The following is a description of a gene set: Cytokines mediate cell-cell communication in the immune system and represent important therapeutic targets. A myriad of studies have highlighted their central role in immune function, yet we lack a global view of the cellular responses of each immune cell type to each cytokine. To address this gap, the authors created the Immune Dictionary, a compendium of single-cell transcriptomic profiles of more than 17 immune cell types in response to each of 86 cytokines (>1,400 cytokine-cell type combinations) in mouse lymph nodes in vivo. A cytokine-centric view of the dictionary revealed that most cytokines induce highly cell-type-specific responses. For example, the inflammatory cytokine interleukin-1β induces distinct gene programmes in almost every cell type. A cell-type-centric view of the dictionary identified more than 66 cytokine-driven cellular polarization states across immune cell types, including previously uncharacterized states such as an interleukin-18-induced polyfunctional natural killer cell state. species: Mus musculus from publication Cui A, Huang T, Li S, Ma A, Pérez JL, Sander C, Keskin DB, Wu CJ, Fraenkel E, Hacohen N (PMID 38057668) Genes negatively differentially expressed in cell type: cDC1 (conventional dendritic cell type 1) upon treatment with cytokine: IFN-α1 in mouse lymph nodes in vivo. Mouse Gene Set: CUI_CDC1_IFNA1_RESPONSE_DN, and this is the list of marker genes: Exosc5, Lamtor2, Foxp1, Fam50a, Ndufs7, Prpf40a, Pdia5, Mrpl57, Snx21, Brd3, Gltp, Psmd2, Pold4, Yeats4, Lmo4, Mink1, Zfp106, Tsc22d3, Prkar2a, Agpat5, Cd300c2, Sec11a, Mrpl12, Fam168b, Wdfy4, Parp1, Eef1e1, Dock2, Grk2, Macf1, Ncor1, Erp29, Kctd12, Fubp1, Hmgb1, Cdc26, H2-DMa, Atp13a3, Rab32, Slc4a7, Rtcb, Unc119b, Pld4 (NCBI Gene Id 217885), Uba52, Shtn1, Camk1d, Nckap1l, Zfp36l2, Glud1, Mrpl52, Ptpre, Lrrk2, Eif4b, Pianp, Ano6, Mrpl34, Itgb7, Uqcr10, Eif3e, Mef2c, Atrx, Ivns1abp, Atp6v0b, Mphosph8, Echs1, Polr1d, Stt3a, Eif4ebp2, Rsl1d1, Hsp90b1, Cbx3, Lyz2, Nap1l1, Set, Ighm, Cd81, Phactr2, Ccr2, Trf, Paip2, Grap2, Bnip3l, Slc25a5, Mapk14, Mak16, Acadm, Polr2f, Clec12a, Pgls, Polr2e, Cers5 (NCBI Gene Id 71949), Ccr5, Laptm5, Nolc1, Atic, P2ry10, Hnrnpa0, Asnsd1, Pes1, Zfp422, Cct2, Naca, Trmt112, Ddx46, Septin3 (NCBI Gene Id 78356), Bmyc, Rtl8a, Llph, Nr2c2ap (NCBI Gene Id 75692), Eif2a, Glrx5, Tubb2a, Ubash3b (NCBI Gene Id 72828), Gpx4, Cdk6 (cyclin dependent kinase 6), Igsf8, Unc119, Mxd4, Sf3b2, Rtl8b, Tmem147, Tmco1, Gspt1 (G1 to S phase transition 1), P4hb, Armc8, Cks2, Mbd3, Banf1, Nfam1, St3gal4, Fth1, Ufsp2, Prdx6, Pabpc1, Timm13, Snrpa, Sec11c, Eif3g, Adss1, Fnbp1, Dhrs7, Lamtor4, Hepacam2, Atp5mc2, Adcy7, Pa2g4 (NCBI Gene Id 18813), Slc1a5, St8sia4, Ap1b1, Rnf130, Cnih4, Ccr9, Tmem238, Ift20, Eeig2, Pgs1 (phosphatidylglycerophosphate synthase 1), Tm9sf3, H2aj, Rnf150, Eef1a1, Rcc2, Creg1, Cnpy2, Coro1a, Syngr2, Gdi2, Nhp2, Vps35, Trp53, Lrwd1, Dnajc2, Eef2, Phb2, Ctnnbip1, Usf2, Kcnq1ot1, Arhgap9, Zftraf1, Eif4a2, Rgs10, Ppig, Kit, Nxf1, Trim28, Stap1, Ucp2, Tubb5, Smc4, Cnbp (NCBI Gene Id 12785), Ifngr1, Sod1, Fam162a, Aimp1, Plekha5, Sgpp1, Parvg, Cd44, Bola2, Hspd1, Nr4a2, Dock10, Ran, Prpf19, Eef1d, Ptpn18, Irak1, Cebpz, Ypel3, Alox5ap, Hint1, Nedd8, Cdk4, Sh3bgrl3, Srm, Sars1, Phf3, Fyb1, Mospd1, Hagh, Mlec, Rgs2, Lyz1, Gpx1, Jun, Epb41l4aos, Tbc1d9, Romo1, Tnrc6b, Trim7, Anp32b, Dusp1, Tbc1d22a, Rp9, Mrps18b, Tmem141, Xpr1, Pten, Krtcap2, Cd37, Pgp, Fcgrt, Ap2a2, Iars1, Rad50, Arhgap18, Tomm40, Ctdp1, Eif3k, Nop58, Apex1, Tm2d2, Xist, Eef1g, Prkcsh, Trps1, Eif2b2, Npm3, Ppp1r14b, Fermt3, Parp8, Ptma, Pdcd4, Dkc1, Matr3, Igsf6, Il16, Sgk1, Ttc39a, Naa38, Clk1, Rnf7, Itga1, Prcp, Slc50a1, Septin11, Scd2, Myo1f, Mri1, Canx, Tomm5, Wipf1, Polr2h, Uqcr11 (NCBI Gene Id 66594), Alcam, Asap1, Upf3b, Atf6b, Hnrnpa1 (NCBI Gene Id 52621), Acss1, Mrpl43, Fxyd5, Ccdc115, Dna2, Arhgap45, Treml4, Bin1, Map3k4, Rrp1, Rassf4, Tnfaip8, Pycr2, Ncf4, Ralbp1, Rack1, Adrb2, Wdr3, Cd9, Tyrobp, Txndc15, Xpa, Gpr68, Impa2, Pop5, Zbtb44, Colgalt1, Hnrnpu, H1f2, Smarca2 (SWI/SNF related, matrix associated, actin dependent regulator of chromatin, subfamily a, member 2), Smarcc1, C1qbp (NCBI Gene Id 28127), Txnl4a, Eif3i, Arap1, Srek1, Proser2 (NCBI Gene Id 99240), Abr, Eif2s3x, Prkra, Cyb5r1 (NCBI Gene Id 96900), Snhg6, Zmiz1, Znrd2, Rrp7a, Ciita, Dut, Tbc1d15 (TBC1 domain family, member 15), Supt5, Fam174a, Cldn1, Ube2c, Srsf11, Cct8, Pdlim2, Ptpn7, Cat, Cd48, Fh1 (fumarate hydratase 1), Tnpo1, Uggt1, Qdpr, D8Ertd738e, Olfm1, Ramp1, Kxd1, Fcgr2b, Klf4, P3h2, Nme1 (NCBI Gene Id 18102), Nsun2, Rbfa, Polr1g, Rab7b, Arhgef6, Arsb, Fau, Kctd14, Emc6, Gpsm3, Ebpl (emopamil binding protein-like), Ptprs, Eif4g1, Inpp5d (inositol polyphosphate-5-phosphatase D), Supt4a (SPT4A, DSIF elongation factor subunit), Pum3, Noc2l, Amz1, Tbl1xr1, Gpi1, Ipo7, Uqcc3, Gcsam, Arhgap5, Trmt1, Hmgn1, Bri3bp, Tm6sf1, Tomm7, Ybx1, Ptpn11, Selenoh (NCBI Gene Id 72657), Znrf2, Vcp, Exosc7, Hnrnpr, Dmac1, Polr2g, Sf3b1, Hdgf, Fos, Snx5, Eid1, Dctpp1, Rnf144b, Klhl24, Klf2, Add3, Glo1, Ubac2, Abhd17a, Cotl1, Myo18a, H2-DMb1, Ccdc88a, Hacd2, Cox7a2l, Egln1, Lipa, Hexa, Sec61b, Syne1, Ctsh, Tpi1, Aph1c, Wdr12, Eif3j1, Ckb, Emp3, Atraid, Txn2, Cyb5a, Irag2, Npm1, Lage3, Ndufb11, Ssr4, Eif3f, Commd8, Snx3, Plbd1, Slc66a2, Nudt3, Fbl, Sgms1, Slc38a1, Cenpv, Ak2, Pglyrp1, Elovl5, Naa50, Nop56, Eif3l, Rnf187, Itgb2, Cdca7l (cell division cycle associated 7 like), Cxcr3, Niban1, Ddx18, Zfp706, Nsa2, Serbp1, Klhl6, Cnih1, Abcd1, Polr2j, Mybbp1a, Fosb, Rnd3, Wasf2, Acsl5, Calm2 (calmodulin 2), Nedd4, Sf3b5, Mtdh, Abce1, Eif3a, Imp3, Ftsj3, Ncl, Nudcd2, Samd1